The following is a description of a gene set: Catalysis of the reaction: an epoxide + H2O = an ethanediol. Mouse Gene Set: GOMF_EPOXIDE_HYDROLASE_ACTIVITY studied in species Mus musculus, and this is the list of marker genes: Akr7a5, Ephx4, Ephx1, Alox15, Ephx3, Lta4h, Ephx2, Alox12